The following is a description of a gene set: Optic disc coloboma A cleft of the optic nerve that extends inferiorly. studied in species Homo sapiens Human Gene Set: HP_OPTIC_DISC_COLOBOMA, and this is the list of marker genes: FZD5, SMO, NAA10, IGBP1, SALL2, ACTG1, PRMT7, TMEM67, ACTB, DDX59, INPP5E, PAX6, C2CD3, NIPBL, KMT2D, RPGRIP1L, BCOR, SPINT2, TMEM216, SALL4, EPCAM, PAX2, PCYT1A, PERCC1, CC2D2A, TRRAP, DDX11, FOXE3, HHAT